The following is a description of a gene set: Tremulousness of the iris on movement of the eye, occurring in subluxation of the lens. Iridodonesis Human Gene Set: HP_IRIDODONESIS studied in species Homo sapiens, and this is the list of marker genes: TEK, CYP1B1, LTBP2, CPAMD8, FBN1, MYOC, ADAMTS17, CHRDL1